The following is a description of a gene set: studied in species Mus musculus from publication Chen Y, Wang X (PMID 31504780) Mouse Gene Set: MIR_3074_5P Genes predicted to be targets of miRBase v22 microRNA mmu_miR_3074_5p in miRDB v6.0 with MirTarget v4 prediction scores > 80 (high confidence targets)., and this is the list of marker genes: Micu1, Htr2c, Agfg1, Lrch2, Aadacl4fm1, Dmrta1, Casp7, Pcsk5, Arhgef33, Lrp11, E130308A19Rik, Klhl20, Eri2, Pramel1, Pdcl, Bace2, Bicd2, Hook3, Wnt5b, Daam1, Bnc2, Zfp85, Vgll3, Eif4e, Kif26a, Mob4, Klrk1, Ttll6, Tnrc6b (NCBI Gene Id 72625), D7Ertd443e, Ehmt1, Hoxa11, Keap1, Srsf3, Reln, Pls1, Swap70, Muc15, Tlcd4 (TLC domain containing 4), Ndfip1, Rdh1, Lrig1, Nr4a3, Epb41l1, Vangl1 (NCBI Gene Id 229658), Lingo4, Rdh9, Sec22b, Rdh16, Sccpdh, Pip4k2a, Ncam1, Dnaaf5, Sp4, Ftsj1, Srgap1, Dbx2, Gria4, Tmem167, Trib2 (NCBI Gene Id 217410), Slc38a4, Tspan2, Aopep, Hnrnpl, Epha5, Nrxn1, Il7r, Ifih1, Aktip, Pbx1, Tnks2, Cdr2, Larp4, Phactr3, Gucy1b2, Gap43, Leprot, Dsc3, Lhfpl3, Gng2, Pip4p2, Tnfsf13b, Cacnb2, Tmx1, Hp1bp3, Cdk4, Ndufa4, Man1b1, Amot, Ccdc117, G3bp1, Nefl, Zdhhc5, Srek1ip1, Cnot4, Itfg2, Phip, Erlin1, Jph4, Rab6a, Nsl1, Mief1 (mitochondrial elongation factor 1), Abraxas2, Mlec, Aida, Scd1, Mycbp2, Frmd7, R3hdm1, Star, Pptc7, Trim39, Cntrl, AI987944, Chrna2, Dkk2 (NCBI Gene Id 56811), Rap1gap2, Dlst, Txlnb